Given this list of marker genes Rictor, Atm, Sgk1 (NCBI Gene Id 20393), Usp7, Chek2, Ppp2ca, Daxx, Ccna2, Rnf34, Trp53, Ppp2r1a (protein phosphatase 2, regulatory subunit A, alpha), Ppp2r5c, Mdm4, Cdk1, Ccng1, Akt1, Uba52rt, Rps27a, Cdk2, Akt2, Mdm2, Ppp2cb, Ubb, Prr5, Ubc, Rffl, Mlst8, Phf20, Ccna1, Uba52, Pdpk1, Akt3 (thymoma viral proto-oncogene 3), Ppp2r1b, Mtor, Usp2, Mapkap1 (NCBI Gene Id 99025), here is a description of the gene set: species: Mus musculus Mouse Gene Set: REACTOME_REGULATION_OF_TP53_DEGRADATION Regulation of TP53 Degradation